The following is a description of a gene set: species: Homo sapiens from publication Fan X, Dong J, Zhong S, Wei Y, Wu Q, Yan L, Yong J, Sun L, Wang X, Zhao Y, Wang W, Yan J, Wang X, Qiao J, Tang F (PMID 29867213) Human Gene Set: FAN_EMBRYONIC_CTX_ASTROCYTE_2, and this is the list of marker genes: C1orf198, AHCYL1, MACF1, TFPI, RIDA, CAMK2G, ACKR3, VSIR, SERPINE2, MFGE8, ALDOC, PCDH10, S1PR1, LAMA4, CFAP276 (cilia and flagella associated protein 276), NFIA, GLUL, NTRK2, MYBPC1, SLC25A18, EFEMP1, NR2F1, SLC15A2, PCDH9, ZFYVE21, TTYH1, NTSR2, BMPR1B, ARHGEF26, MT3, AQP4, SESN3, CLU, MT1F, ALDH1L1, HSD17B6, RORA, GJA1, ABCA1, COL6A1, ACSL6, GLUD1, HACD3, SPATS2L, EZR, SSPN, B4GAT1, TMEM47, VCAM1, ASPH, DDIT4, HTRA1, GRAMD2B, NDRG2, TIMP3, FUT9, LIX1, GPC5, BBS2, ITPR2, PMP2, SLC1A2, CD44, PLXDC2, SLC1A4, SPON1, APC, SDC2, RAMP1, HIF3A, ST8SIA1, MT1E, SLC39A12, GJB6, TMT1A, PRODH, ENTREP1, LUZP2 (NCBI Gene Id 378943), FIBIN, KMT2C, GABBR2 (NCBI Gene Id 9568), RIC3, HAPLN3, SPMIP6, PDLIM5, F3, CDO1, SEMA6D, MT2A, APOE, NHSL1-AS1, ID4, TPPP3, TRIL, GDPD2, PLSCR4 (NCBI Gene Id 57088), GASK1B, MARCKS, ANOS1, GABBR1, LAMA1, DST (dystonin), CACHD1, MT1M, SPOCK2, NFIB, PLPP3, GABRG1, BBOX1, LINC00844, MT1X, FBLN1, DDAH1, ATP1B2, CTNNA2, KCNN3, OAT, FGFR3, PTTG1IP, NPC2, PLTP, ALCAM, ATP1A2, GARNL3, LGR4, EDNRB, MSMO1, SLC4A4, CSGALNACT1, ADIRF, SLC7A11, MGST1, NR2F2, CAPS, DTNA, LIFR, CPE, PBXIP1, ADGRG1 (adhesion G protein-coupled receptor G1), LAPTM4A, AK1, AIFM3, DNER, SLITRK2, NRCAM, IQCA1, FAT3, SLC3A2, SH3GL2, SOX2, ETNPPL, PSD2, ITM2C, WLS